Given this list of marker genes CCNG2, CBX4, EDRF1, CXCL3, PLEKHA2, GGNBP2, CCKAR, IL15, CNOT2, RABEP1, ADGRA3, MKRN2, SRP14, TMBIM1, AATF, DNAJC10, MRPL44, RCOR1, CLEC3B, BBOX1, TRIM33, SPRYD7, CUL4B, KRT2, SPECC1, ART3, LZTFL1 (NCBI Gene Id 54585), CASP2, ERMP1, RBM10 (RNA binding motif protein 10), ARRB2 (arrestin beta 2), XAB2, DDX54, CHEK1, TINF2, DDX20, UBE2F, ALDH9A1, DEK, ZFP36L2, EOMES, PTCD3 (NCBI Gene Id 55037), PTPA, USP7, ATAD2B, GEM, C6orf132, EPS15, ICE1, CLASP1 (cytoplasmic linker associated protein 1), CLASRP, ZMYM3, ENTPD4, MT1E, ATF2, C9orf40, ACADM, PSMA8, ASPRV1, ZNF394 (zinc finger protein 394), TMX2, SMARCD2, ANXA2, TRIM41, RPAP3, GPRASP1, SMARCA2, ETFBKMT, RAP2A, MORN4, BTBD1, HNRNPK, PIP5K1C, RIF1, PNRC1, PELO, FAM133B, PDCD2, NAAA, HERC4, MPP7, SATB1, AIFM1, CDK5RAP1, ETNK1, DRG1, RPP14, MCM3AP, GTF3C4, CDT1, CASR, SAFB, KPNB1, C5orf22, ATP11A, EIF2AK4, LSM14B, GALNT11, PRPF39, HCFC1R1, SPINK4, DHCR7, ABHD17C, CRAMP1, TTI1, ATP7A, DCP1A, RNFT1 (ring finger protein, transmembrane 1), KLHDC2, STX5, LAMP1, METTL23, ZFP36L1, NCKAP1L, IARS2, REV3L, MARVELD1, KDM3A, PLEKHA7, GOSR2, DDB2, XPO7, CGGBP1, BIRC2, WDR82, PSTK, GDI1, POLI, DCTN4, IDH3G, PCNX4, SPAST, SMC5 (NCBI Gene Id 23137, structural maintenance of chromosomes 5), SLC25A20, UBP1, BLTP1, GSDME (NCBI Gene Id 1687), ZNF704, SMAP1, MECP2, CYFIP1, GP1BA, CFAP20, ATP6AP1, OCSTAMP, ING2, SYF2, TRAPPC10, ADAM17, SCYL1, STAT4, ZBTB14, VPS4B, CFAP141, EPC1, ZMYND8, DHX40, USP1, PI15, CCNE1, RPL14, CPPED1 (calcineurin like phosphoesterase domain containing 1), MYADM, TOB2, RECK, RAB14, BCLAF1, SLC10A3, RAB6B, NAF1, TLCD4, STXBP3, SOCS6, TMEM230 (transmembrane protein 230), ANTXR2 (ANTXR cell adhesion molecule 2), FAM76B, HEATR1, PER2, TMEM87A, FAM76A, YTHDC1, MLLT11, EID1, TCF12, MYLIP, GPR89B, CPE, RNF2, ORC6, SLC25A46, TADA1, BIRC3, ACTR6, MIA3, SDR42E1, FXYD2, SLAIN2, PIGH, DMAC2, ETFDH, here is a description of the gene set: Human Gene Set: GSE12001_MIR223_KO_VS_WT_NEUTROPHIL_DN Genes down-regulated in neutrophils: MIR223 knockout versus wildtype. from publication Baek D, Villén J, Shin C, Camargo FD, Gygi SP, Bartel DP (PMID 18668037) studied in species Homo sapiens This array analysis is to study the regulation of target messages’ expression in murine neutrophils versus miR-223 null neutrophils.